Given this list of marker genes Pgr, Hnrnpu (heterogeneous nuclear ribonucleoprotein U), Cdk5, Grk2, Supt7l, Ciz1, Taf3, Arl2bp, Sp100, Taf8, Skp1, Hdac3, Rangap1, Nr5a1, Bard1, Sun1, Syne1, Bbs4 (NCBI Gene Id 52291), Fam76b, Pml, Topors, Txn1, Morc3, Arl2, Park7, Sun2, here is a description of the gene set: Mouse Gene Set: GOBP_MAINTENANCE_OF_PROTEIN_LOCATION_IN_NUCLEUS Any process in which a protein is maintained in the nucleus and prevented from moving elsewhere. These include sequestration within the nucleus, protein stabilization to prevent transport elsewhere and the active retrieval of proteins that escape the nucleus. studied in species Mus musculus